Given this list of marker genes Acacb, G6pc2, Nfe2l1, Bckdk, Wdtc1 (WD and tetratricopeptide repeats 1), Mup5, Epm2aip1, Pth, Nnmt, G6pc3, Lcmt1, Pdk1, Hk3, Eno1, Pgam1, Npy1r, Oma1, Gnmt, Phkg1, Pdk2 (pyruvate dehydrogenase kinase, isoenzyme 2), Ddb1, Slc25a11, Gapdhrt, Serp1, Cbr2, Pgm2l1, Adipoq, Hectd4, Rorc, Fbp2, Rora, Zmpste24, Actn3, Adra1b, Rbp4, Gck, Pgam2, Ins2, Mdh2, Eno3, Lepr, Pkm, Pmaip1, Gdf2, Crtc2, Phkb (NCBI Gene Id 213944), Dgat2, Oas1b (2'-5' oligoadenylate synthetase 1B), Igfbp3, Adipor1, Oas1c, Oas1g, Fgl1, Slc37a4, Hmgb1, Zfp692, Errfi1, Slc2a8, Snord33, Ins1, Gapdhrt2, Kat2b, Mup3, Nkx1-1, Ncoa2, C1qtnf1, Pdhb, Esrrb, Pfkfb2, C1qtnf3, Gcg, Pck2, Lep, Mup4, Pgp, Mup1, Sirt1, Gpt, Ppara, Serpina12, Prkag3, Pfkfb1, Bad, Foxk1, Prkaa1 (NCBI Gene Id 105952), Insr, Tpi1, Fam3a, Aldoc, Car5a, Apod, Arpp19, Prkag1, Atf4, Hkdc1, Cpt1a, Hk2, Tcf7l2, Ldha, G6pdx, Sik1, Oas1h, Oas1d (NCBI Gene Id 97256), Trp53, Nisch, Gpd2, Gpi1, Gpd1, Pdha1, Nr3c1, Dlat, Igf1, Supt20, Tnf, Pik3ca (phosphatidylinositol-4,5-bisphosphate 3-kinase catalytic subunit alpha), Bcl2l13 (BCL2 like 13), Slc45a3, Sds, Foxo1, Irs2, Pcx, Ppp1r3g, Pfkl, Lrp5, Aldob, Phka1, Aldoa, Ptpn2, Mlycd, Dyrk2, Dgkq, Nln, Sirt7 (NCBI Gene Id 209011), Pgk1, Clk2, Tff3, Gapdhs, G6pd2, Ppp4r3a, Obp2a, Akt2, Kbtbd2, Slc25a13, Pfkp, Angptl8, Hnf4a, Ep300, Gnb3 (guanine nucleotide binding protein (G protein), beta 3), Ppp1r3b, Fbp1, Cyp2j6, Erfe, Mir143, Ppargc1a, Mup11, Kcnj11, Rgn, Got1, Akt1, Onecut1, Xpc, Ranbp2, Hk1, Snord35a (NCBI Gene Id 27211), Sirt6, Tigar, Ganc, Mdh1, Lipa, Gapdh, Il6, Igfbp4, Snord34, Mtcl2, C1qtnf2, Kat2a, Mapk14, Phkg2, Stk11, Adora2b, Ppp1r3e, Usf1, Atf3, Foxk2 (NCBI Gene Id 76149), Gdpgp1, Pgk2, C1qtnf12, Pgm1, Sesn2, Adcy10, Pik3r1, Prkag2, Tfap2b, Oas1a, Src, Brat1, Ogt, Slc25a10, Snord32a, Igf2 (insulin-like growth factor 2), Oas1e, Slc39a14, Pdha2, Wdr5, Cry1, Inppl1, Kcnq1, Galm, H6pd, Mup2, Pdk4 (pyruvate dehydrogenase kinase, isoenzyme 4), Pfkm, Fbn1, Prkaca, Hif1a, Myc, Eno1b, Mst1, Acadm, Gpt2, Pdk3, Fabp5, G6pc1, Dcxr, Usp7, Irs1, Oprm1, Mir423, Sorbs1, Ppp4r3b, Pck1, Bola3, Slc25a12, Pgm2, Pdx1, Adpgk, Ppp1ca, Slc35b4, Oas1f, Eno2, Per2, Gpld1, here is a description of the gene set: studied in species Mus musculus The chemical reactions and pathways involving glucose, the aldohexose gluco-hexose. D-glucose is dextrorotatory and is sometimes known as dextrose; it is an important source of energy for living organisms and is found free as well as combined in homo- and hetero-oligosaccharides and polysaccharides. Mouse Gene Set: GOBP_GLUCOSE_METABOLIC_PROCESS